Given this list of marker genes Jun, H2-Aa, Cd74, Hspa1b, Tsc22d3, Hspa1a, here is a description of the gene set: studied in species Mus musculus Genes negatively differentially expressed in cell type: CD4+ T cell upon treatment with cytokine: RANKL in mouse lymph nodes in vivo. Cytokines mediate cell-cell communication in the immune system and represent important therapeutic targets. A myriad of studies have highlighted their central role in immune function, yet we lack a global view of the cellular responses of each immune cell type to each cytokine. To address this gap, the authors created the Immune Dictionary, a compendium of single-cell transcriptomic profiles of more than 17 immune cell types in response to each of 86 cytokines (>1,400 cytokine-cell type combinations) in mouse lymph nodes in vivo. A cytokine-centric view of the dictionary revealed that most cytokines induce highly cell-type-specific responses. For example, the inflammatory cytokine interleukin-1β induces distinct gene programmes in almost every cell type. A cell-type-centric view of the dictionary identified more than 66 cytokine-driven cellular polarization states across immune cell types, including previously uncharacterized states such as an interleukin-18-induced polyfunctional natural killer cell state. from publication Cui A, Huang T, Li S, Ma A, Pérez JL, Sander C, Keskin DB, Wu CJ, Fraenkel E, Hacohen N (PMID 38057668) Mouse Gene Set: CUI_T_CELL_CD4_RANKL_RESPONSE_DN